Given this list of marker genes Rxrb, Vdr, Rxra, Kank2, Snw1, Trim24, Med1, Snai2, Mn1, Cyp27b1, here is a description of the gene set: studied in species Mus musculus Any process that modulates the frequency, rate or extent of vitamin D receptor signaling pathway activity. Mouse Gene Set: GOBP_REGULATION_OF_VITAMIN_D_RECEPTOR_SIGNALING_PATHWAY